Given this list of marker genes Mmrn2, Lamb1, Tnr, Vtn (vitronectin), Emilin1 (NCBI Gene Id 78939), Plau, Lamb2, Emilin2, Lama2, Plaur, Tnn, Tnc, Nid1, Lamc1, Lama1, Mmrn1, here is a description of the gene set: Any protein complex that is capable of carrying out some part of the process of cell-matrix adhesion. species: Mus musculus Mouse Gene Set: GOCC_PROTEIN_COMPLEX_INVOLVED_IN_CELL_MATRIX_ADHESION